The following is a description of a gene set: Human Gene Set: STAT1_03 Genes having at least one occurrence of the motif NNTTTCCN in the regions spanning 4 kb centered on their transcription starting sites. This matches the STAT1 transcription factor binding site V$STAT1_03 (v7.4 TRANSFAC). studied in species Homo sapiens, and this is the list of marker genes: SKP2, SMARCA1, NUDCD1, EPHB2, RDH11 (NCBI Gene Id 51109), CD9, EIF4G1, MIR17HG, FEM1A, AKIRIN2, VPS41, SKA2, LINC00955, PPP2CB, ARL4C, HOXB2, SLC30A3, FOXG1, DDX47, MYH10, GDF7, SREK1, EHBP1, LRP5, HOXB6, ADAP2, VEZF1, PYY, AMTN, EN1, ALKBH8, PAX6, CALHM1, SRSF2, PUS3, CNTN6, DNAJC5G, GRIK1, SLC26A10P, SLC9A1, ZNRF1, PRPF19, DOCK3, NUCB1, STX6, COX8A, DIP2B, HSD11B1L, STC1, RAB2A, FBRS, GNG4, PLCB2, CRK, TBX5, CHMP2A, RPL28, CSNK1A1, BABAM1, EGF, PCDHGB5, SYNE1, PDE6D, POMC, INO80D (NCBI Gene Id 54891), MON1A, HOXC4, INTS9, GPATCH2L, DNAJA2, COQ8B (coenzyme Q8B), NCOA3, GRIA1, FAM20B, HSPD1, ARL6IP5, SEMA4B, IFTAP, NTRK3, NLK, ZCCHC24, PCF11, ZNF420, SLITRK3, VAX1, ZNF571, PCED1B, IL23A, RPS27, E2F3, COL16A1 (NCBI Gene Id 1307), DCAF1, NHLH2, RBM4B, ARHGEF15, ZFP2, HNRNPA2B1 (NCBI Gene Id 3181), HMBOX1, NBR2, NSD3, ZNF546, CLDN5, FBXO11, MARS1, CHD4, DMD, ARPC1B, GFI1, PIK3CD, ARMC8, CS, EXTL3, PPP1R9B (NCBI Gene Id 84687), ZNF570, SMPD3, ZNF582, UBE2N, PREPL, BDNF, DTX2 (NCBI Gene Id 57652), AFP, IRF1, ZNF471, ITM2C, CDK6, DRC7, HSD17B4 (NCBI Gene Id 3295), BET1, GADD45B, BCLAF1, RHOG, GABRA1, SYMPK, GATA3, SCN2B, DHH, PABPN1, TMED5, RNF220, RAPH1, VCAM1, CAB39, GSK3A, TCERG1, ZNF569, SH2B3, LIX1, AJUBA, WWOX, OR1A1, ARHGAP9, NKX2-8, EIF2B4, EP300, APPL1, CSRNP2, H1-0, CREBRF, RAB8B (RAB8B, member RAS oncogene family), EPHA1, OLFM4, MRPL54, PSMC3, IGFALS, FBXW11, STX16, CCND1, RELA, MICOS13, SHKBP1, CAMKMT, LRFN4, ODF1, GSPT1, TJAP1 (NCBI Gene Id 93643), ITPKC, SNX17, CCR4, DDR1, CBX3, NRG1, PRR11, WBP1L, MRPL34, GNB3, MED15, ERG, ADAM22 (ADAM metallopeptidase domain 22), POC1A, TLK2, RCOR2, CCNI, HIVEP3, DDX25, MPI, TTC1, SCNM1, ZAP70, SNX9, SIN3A, CTDSPL2, DLL1, KLK9, BRCA1, C4BPA, ERF, GRK5, CHRM1, NRGN, FOXA3, LYVE1, HDAC9, PPP2R2C, NXPH4, JADE2, GALK2, GALR3, SOX4, PDE4D, SPTLC2, PI4KB, DLX1, SLAMF1, VGF, ZNF385A, ZNFX1, PCYT2, TRAF4, ZNF568, FITM1, MIR137HG, LYSMD1, RGS17, SALL1, MAP3K8, PRKACA, SYT6, SEC14L2, MAG, HHEX, RTL9, BRINP3, GRIN2B, USP2, DDA1, PRPF38B, ELOVL6, POLR1B, HSPE1, APBA3, NFKBIZ, UBL3, IKZF4, MEX3B